The following is a description of a gene set: species: Homo sapiens Human Gene Set: REACTOME_INITIAL_TRIGGERING_OF_COMPLEMENT Initial triggering of complement, and this is the list of marker genes: IGHV4-59, IGKV2D-40, IGHV4-39, IGLV2-8, IGLV1-51, IGHV1-46, C1QC (complement C1q C chain), CFD, IGKV1-39, C1S, C1R (complement C1r), IGKV1-16, IGHV3-33, IGKV1-17, IGKV1-5, IGLV7-43 (immunoglobulin lambda variable 7-43), IGLV6-57, IGHV3-7, IGLC3, IGKV4-1, IGLV2-14, IGLV1-44, C1QB, MASP2, IGHG4, IGKV5-2, FCN1, IGKV2-30, IGHV1-2, IGHG1, IGLV2-11, C4B_2, CRP (NCBI Gene Id 1401), MASP1, IGHV4-34 (NCBI Gene Id 28395), IGHV2-70, IGKV3D-20, C3, IGKV1-33, IGHG2 (immunoglobulin heavy constant gamma 2 (G2m marker)), IGKV1D-39, GZMM, IGHV3-30, IGLC2, IGLV3-27, IGHV3-48, C1QA, MBL2, COLEC10, COLEC11, IGHV2-5 (NCBI Gene Id 28457), IGKV2D-30, IGLV1-47 (NCBI Gene Id 28822), C4A, IGLV2-23, IGKV3-15, CFP, IGLV3-19, IGLV3-25, IGKV1D-16, IGHV3-13, FCN3, IGHV3-23, CFB, IGKV2D-28, C4B, IGLV1-40, C2, IGKV2-28, IGLV3-21, IGKV3-20, IGHV3-53, IGKV1-12, IGHV3-11, IGHV1-69, IGKV1D-33, IGKV1D-12, IGLV3-1, FCN2, IGKV3-11